The following is a description of a gene set: The dendritic cell (DC) is a master regulator of immune responses. Pathogenic viruses subvert normal immune function in DCs through the expression of immune antagonists. Understanding how these antagonists interact with the host immune system requires knowledge of the underlying genetic regulatory network that operates during an uninhibited antiviral response. In order to isolate and identify this network, we studied DCs infected with Newcastle Disease Virus (NDV), which is able to stimulate innate immunity and DC maturation through activation of RIG-I signaling, but lacks the ability to evade the human interferon response. To analyze this experimental model, we developed a new approach integrating genome-wide expression kinetics and time-dependent promoter analysis. We found that the genetic program underlying the antiviral cell state transition during the first 18-hours post-infection could be explained by a single regulatory network. Gene expression changes were driven by a step-wise multi-factor cascading control mechanism, where the specific transcription factors controlling expression changed over time. Within this network, most individual genes are regulated by multiple factors, indicating robustness against virus-encoded immune evasion genes. In addition to effectively recapitulating current biological knowledge, we predicted, and validated experimentally, antiviral roles for several novel transcription factors. More generally, our results show how a genetic program can be temporally controlled through a single regulatory network to achieve the large-scale genetic reprogramming characteristic of cell state transitions. from publication Zaslavsky E, Hershberg U, Seto J, Pham AM, Marquez S, Duke JL, Wetmur JG, Tenoever BR, Sealfon SC, Kleinstein SH (PMID 20164420) Genes up-regulated in comparison of control conventional dendritic cells (cDC) at 0 h versus cDCs infected with Newcastle disease virus (NDV) at 6 h. Human Gene Set: GSE18791_CTRL_VS_NEWCASTLE_VIRUS_DC_6H_UP species: Homo sapiens, and this is the list of marker genes: NAPEPLD, MTMR12, CSTF2T, RIC8A, ATPSCKMT, GLYATL1, NIFK-AS1, ELK3, NLRP2, MRPL10, THNSL1, SLC38A4-AS1, ABHD15, RANGRF, PTCD2 (NCBI Gene Id 79810), P2RY13, ZNF641, BAHD1, ARV1, PDE6D, TFB2M, MAP7, TRIM32 (tripartite motif containing 32), HENMT1 (HEN methyltransferase 1), NIP7, TBL2, TNRC18, TLR6, UTP23, NME6, SNRNP35, MFSD5, ENDOG, TRIM35, RPP40, RFXANK, CTPS1, URB2, SLC39A3, CRADD, DCAF4, DDX28, CRLS1, ATG101, FBXO21, HMBS, SARS2, POLR1E, PUS1, NOP2, PDIK1L, TMEM168, PPAT, FAM98B, VSIG1 (V-set and immunoglobulin domain containing 1), HMG20A, NUDT6, UBAC1, NCBP2AS2, ZFP3, MSH2, PDCD7, ECE2, CAD, KRT5, FAM114A1, FLVCR2, OSGEPL1, MTFR2, CCNE1, EBPL, RPAP2, BLOC1S4, SLC25A11, KAT14, DPH5, ELP6, WNT4, CCDC126, GEMIN7, ZNF35, SLC17A9, DCAF13, MRTFA, SAMD13, MPLKIP, CETN2, FKBP14, RHNO1, SEC13, MBLAC2, SRP68, WNT5B, AKTIP, RBBP9, ZFP1 (NCBI Gene Id 162239), MED29, DNAAF2, RRS1, BRF2, TMEM147, DDIAS, THYN1, RUNX1, TARBP2 (NCBI Gene Id 6895), FLAD1, PPP1R14B, PRADC1, TOMM40L, FLVCR1-DT, RLIG1, RIPOR1, XXYLT1, TSEN2, ASTE1, MRPL12, PLPP6, MTFMT (mitochondrial methionyl-tRNA formyltransferase), HHEX (NCBI Gene Id 5556), ZNF460, RMND1, DBP, GSPT2, PEX1, ZSCAN5A, DUS2, KCTD21, CCDC85B, APEX1 (NCBI Gene Id 328), MTFR1, SMIM26 (NCBI Gene Id 388789), POLR3H, NXT1, TWF2, PRMT5, YLPM1, TMEM87B, SLC25A12 (NCBI Gene Id 8604), ZNF77, ZNF302, IFFO2, METTL18, MRPL4, EXO5, NAIF1, IFNGR1, GMPS, BRIX1, GXYLT1, SWSAP1, ZNF561, STUB1, FRAT2 (NCBI Gene Id 93368), IL16, NDUFA5, IRAG2, GET1, EXOSC2, BYSL, LRRC20, TEX264, ZNF57, KIAA0586 (KIAA0586), NAPG, BIN3, TMEM115, DNAJC11, SMIM12, NUDT22, MRPL36, HYCC1, CETN3, DHRS4-AS1, NIT2, FOS, HRH1, POLR1G, SUV39H2, WDR53, MRPS2, RNF7, LYSMD3, ASB6, HVCN1, IMPDH2, ZNF317, TTLL1, ZNF280D (NCBI Gene Id 54816), KBTBD7, ZCCHC24, ZNF319 (zinc finger protein 319), PDRG1, ATPAF2, ARB2A, CCDC12, CLP1, POLE3, NELFCD, CIAPIN1, UNG